The following is a description of a gene set: Human Gene Set: WP_REGULATION_OF_WNT_BCATENIN_SIGNALING_BY_SMALL_MOLECULE_COMPOUNDS Regulation of Wnt / B-catenin signaling by small molecule compounds studied in species Homo sapiens, and this is the list of marker genes: DVL2, TNKS, TCF4, APC, SFRP4, LRP1, GSK3B, FZD7, MBOAT1, CTNNB1, FZD8, WNT1, DKK3, LEF1, FZD1 (NCBI Gene Id 8321), CSNK1A1 (NCBI Gene Id 55416), AXIN1